Given this list of marker genes SPARC, STAB2, APOB, STAB1, here is a description of the gene set: studied in species Homo sapiens Reactome Pathway: Scavenging by Class H Receptors STAB1 (FEEL-1) and STAB2 (FEEL-2) are very large transmambrane proteins containing fasciclin domains, EGF-like domains, and hyaluronan-like domains. part of: Binding and Uptake of Ligands by Scavenger Receptors